Given this list of marker genes ADIPOQ, PTPN2, C1QC, INHBA, INHA, TAOK3, GATA2, ZBTB46, QKI, MIR486-1, here is a description of the gene set: species: Homo sapiens Human Gene Set: GOBP_NEGATIVE_REGULATION_OF_MACROPHAGE_DIFFERENTIATION Any process that stops, prevents, or reduces the frequency, rate or extent of macrophage differentiation.